The following is a description of a gene set: species: Homo sapiens The series of events by which a muscle stretch stimulus is received by a cell and converted into a molecular signal. Human Gene Set: GOBP_DETECTION_OF_MUSCLE_STRETCH, and this is the list of marker genes: CAV3, CTNNB1, CSRP3, TCAP, CDH2, TTN, PTK2